The following is a description of a gene set: Human Gene Set: GOBP_CELL_MATRIX_ADHESION The binding of a cell to the extracellular matrix via adhesion molecules. species: Homo sapiens, and this is the list of marker genes: ITGA8, VCAM1, ADAMTS9, MIR29C, PARVG, POSTN, PHLDB2 (pleckstrin homology like domain family B member 2), ITGA9, FUT1, PLEKHA2, MIR939, ITGB1BP1, BCL2L11, DEFB118, DMTN, ITGB5, CORO2B, PTPRJ, ITGB2, ITGA2B, NID1, PPFIA1, NF1 (neurofibromin 1), EFNA5, ACTN1, COL5A3, MAP4K4, WHAMM, JAG1, PKHD1, CCL25, ACTN3, SFRP1, ITGB8, LYPD3, ITGA3, VWA2, ITGA11, LYVE1, ITGB7, PIP5K1A, LIMS1 (NCBI Gene Id 3987), CD96, EMP2, CDKN2A, EMILIN1, TNXB, TRIP6, DAG1, BST1 (bone marrow stromal cell antigen 1), ITGB4, SMAD3 (NCBI Gene Id 51521), ONECUT2, SVEP1, MIR92A1, PTEN, MADCAM1, MINK1, MYF5, PIK3CB, ANXA2, NPNT, PKD1, FGA, JAM3, LIMCH1, COL16A1, LEF1, SGCE, CD34, OTOA, FGB, PTK2B, SORBS1, COL17A1, CIB1, TECTA, EPHA3, THBS1, PIK3R1, CD36, TEK, L1CAM, CCR7, UTRN, CFL1, TIMM10B, JUP, TMEM8B (transmembrane protein 8B), SRF, TRPM7, ADAM9, RCC2, CD63, STRCP1, ITGA7, ITGAM, ITGAE, MKLN1, VTN, ITGB1, HOXA7, FERMT2, GPM6B, ITGA10, CCN2, RHOA, DLC1, ONECUT1, CDH13, SRC, DAPK3, LDB1, CTNNB1, ITGA2, COL13A1, EFEMP2, CTTN, PEAK1, SLK, PECAM1, FERMT3, CASK, ADAMTS12, EDA, COL3A1, ITGBL1, SEMA3E, ACER2, ARHGEF7, SLC9A1, WDPCP, TAOK2, CD44, MMP12 (matrix metallopeptidase 12), NF2, NRP1, RASA1, CEACAM6, RAC1, CSF1, MIR192, PTPRA, ACTN2, RRAS, ROCK2, CDK5, ITGB3, TSC1, ZYX, CLASP2, BCR, CDK6, TIAM1, PLPP3, ACTG1, POLDIP2, WNT4, FGG, HOXD3, EPDR1, VCL, FREM1 (FRAS1 related extracellular matrix 1), CORO1C, ROCK1, DUSP22, DUSP3, SKAP1, BCAM, RIN2, ADAMTS13, TLN1, ANGPTL3, CDH11, ITGAX, ECM2, ITGA4, GREM1, ITGA6, CD3E, AJUBA, FERMT1, THBS3, CAMSAP3, SERPINE1, NID2, VEGFA, APOD, CCL21, STRC, THSD1 (thrombospondin type 1 domain containing 1), ITGAV, CCL28, ILK, ARHGAP6, ABL1, MYOC, EPHA1, CX3CL1, ITGA5, HRG, MACF1, PLET1, PPFIA2, PTK2, BCL6, STON1, BCL2, ITGAL, ADAM15, FBLN5, MSLNL, EPB41L5, MUC4, CLASP1, THY1, PLAU, SNED1, TESK2, FN1 (NCBI Gene Id 2335), AJAP1, DISC1, FAM107A, GSK3B, ITGAD, S100A10, MMP14, NEXMIF, RHOD, SIGLEC1, ITGA1 (integrin subunit alpha 1), HPSE, PPM1F, GFUS, DDR1, SDC4, ITGB6, TNN, PTPRK, ACVRL1, MSLN, KDR